Given this list of marker genes Rigi, Psmd2, Yy1, Tomm70a, Usp8, Usp33, Traf3, Stam2, Psmd11 (proteasome (prosome, macropain) 26S subunit, non-ATPase, 11), Tgfbr1, Rnf128, Usp5, Kat2a (NCBI Gene Id 76912), Mbd6, Ddb2 (NCBI Gene Id 72138), Bap1, Usp3, Actr5, Trp53, Usp17la (NCBI Gene Id 13531), Becn1, Mdm4, Rps27a, Actl6a (NCBI Gene Id 99742), Mcrs1, Tfpt, H2ac20, Otub2, Rnf146, Cdc25a, Tnip3, Psma2, Psmd1, Tnip2, Vdac2, Ccna1, Usp18, Ptrh2, Ubb, Usp16, Tnks2, Usp17ld, Babam1, Arrb2, Usp4, Psmb1 (proteasome (prosome, macropain) subunit, beta type 1), Adrm1, Suds3 (NCBI Gene Id 71954), Psmb2, Usp7 (ubiquitin specific peptidase 7), Usp19, Foxo4 (forkhead box O4), Rnf123, Psmd6, Nfkbia, Usp28, H2ac21, Asxl1, Trrap, Smad7, Traf2, Usp25, H2ac1 (H2A clustered histone 1), Skp2, Usp34, H2ac4, Nod2, Keap1, Foxk1, Usp42, Vdac1 (NCBI Gene Id 22333), Atxn7, Psma6, Uchl5, Usp20, Tada3, Tnks, Ufd1, Clspn, Bard1, Ep300, Brcc3, Foxk2, Apc, Smurf2, H2ac11, H2ac18, Nod1, Psmb7, Mbd5, Arrb1, Smad3, H2ac19 (H2A clustered histone 19), Psmb6, Nedd8, Tnfaip3, Ino80, Psmc4, Uchl3, Vcp, Psmd13, Esr1, Ube2d1, Axin2, Ar (NCBI Gene Id 11835), Snx3, Nfrkb, Axin1, Psmc6, Abraxas2, Psma3, Ccp110, Otud7a, Usp26, Psma4 (NCBI Gene Id 26441), Smad2, Ino80b, Pten, Usp17lb, Usp24, Ripk2, Yod1, Ruvbl1, H2aj, Psmd14, Otud3, Psmd8, Smad1, Psma7, Atxn3, Myc, H2ac24, Usp48 (NCBI Gene Id 72765), Usp15, Nlrp3, Usp10, Il33, Usp12, Rce1, Fkbp8, Usp44, H2ac25, Prkn, H2ac7, Uba52rt, H2ac10, Polb, Hcfc1, Usp17lc, Mat2b, Uba52, Psma5, Ikbkg, Josd2, Birc2, Ogt, Taf9b, Psma1, Cyld, H2ac8, Rad23b, Usp30, Psmb3, Rad23a, Smad4, Psmc2, Usp17le, Vdac3, Ino80c, Senp8, Asxl2, Abraxas1, Tab1, Ide, Ubc, Ino80e, Wdr48, Mul1, Usp47, Traf6, Psmd3, Usp13, Actb, Rhoa, Kdm1b (lysine (K)-specific demethylase 1B), Psmb4, Cdc20, Tomm20, Gata3, Cdk1, Usp2 (NCBI Gene Id 53811), Ifih1, Tada2b, Taf10, Josd1, Stambpl1, Usp29, Mdm2, Tnip1, Birc3, Otud7b, H2ac22, Hgs, Usp9x, Brca1, Adrb2, Psmc3, Actr8, H2ac6, Psmd12, Siah2, Otub1, H2ac12 (H2A clustered histone 12), Usp37, Psmc1, Psmb5, Uchl1, Stambp, Stam, Zranb1, Map3k7 (NCBI Gene Id 93774), Babam2, Psmd7, Ccna2, Mysm1, H2ac15, Usp14, Ripk1, Hif1a, Wdr20, Usp22, Usp21, Cftr, Usp11, Ino80d, Vcpip1 (NCBI Gene Id 70675), Rhot1, Psmc5, H2ac13, Uimc1, Kat2b, H2ac23, here is a description of the gene set: Mouse Gene Set: REACTOME_DEUBIQUITINATION species: Mus musculus Deubiquitination